The following is a description of a gene set: studied in species Homo sapiens Human Gene Set: GOCC_CULLIN_RING_UBIQUITIN_LIGASE_COMPLEX Any ubiquitin ligase complex in which the catalytic core consists of a member of the cullin family and a RING domain protein; the core is associated with one or more additional proteins that confer substrate specificity., and this is the list of marker genes: KLHDC10, DCAF7, FBXO17, CUL9, KLHL5, LRRC75A, SPOPL, FBXL16, FBXL6, ZSWIM5, DTL, FBXL13, FBXL3, KLHL12, CUL1, PRAMEF14, PRAMEF8, KCTD10, PRAMEF1, CRBN, KLHL18, FBXL21P, ANAPC15, FBXO31 (NCBI Gene Id 84204), DCAF11, BTRC, DMAC2, ANAPC7, KBTBD2, KLHL4, DDB2, CCNF, PRAMEF13, ARMC5, KLHL29, ARIH2, LZTR1, KLHL15, KLHL7, FBXO46, CCIN, KLHL40, FBXL7, DCAF1, FBXO44, SOCS2, PRAMEF11, PRAMEF10, CUL2, FBXO48, FZR1, KLHDC1, KLHL42, DCAF12L1, CUL7, FBH1, DDB1, CUL4A, FBXO9, ANAPC16, RNF7, ANAPC1, KLHL41, ANKRD9 (NCBI Gene Id 122416), PRAMEF6, KLHL24, SPOP, FBXO15, CDC16, DCAF13, FBXO39, SPSB1, PRAMEF15, KLHL28, FBXL15, KLHL25 (kelch like family member 25, NCBI Gene Id 64410), CKS2, KLHL13, DCAF4, FBXO42, TMEM183BP, WDTC1, ANAPC13, PRAMEF4, KCTD2, GLMN, FBXL14, KLHL6, USP47, UBE2C, PRAMEF12, KLHL11, PRAMEF27, PRAMEF26, PDCD6, WDR77, DCAF10, TNFAIP1, FBXW7 (NCBI Gene Id 55294), IVNS1ABP, FEM1C, CUL3, KLHL1, DCAF8L2, SKP1, BUB1B, KLHL3, KLHL35, ZSWIM8, PRAMEF20, APPBP2, KCTD13, CACYBP, CUL4B, KLHL38, ZER1, FEM1B, FBXW4, PRKN, FBXO4, KLHL23 (kelch like family member 23), FBXO7 (F-box protein 7), FBXO2, FBXW5, ARIH1, PRAMEF19, ZYG11B, CAND1, TRIM21, ELOC, KEAP1, ASB11, DCAF6, FBXO38, FBXO3, ANAPC2, KLHL2, PRAMEF7, FBXO6, KLHL30, COMMD1, CDC27, PRAMEF18, KBTBD8, ZSWIM4, PRAMEF17, ANAPC11, CDKN1B, DCAF17, SPSB3, ANAPC4, FBXO25, KBTBD12, FBXL17, TRPC4AP, ZSWIM6, DCAF12L2, DCAF8, DCAF16, KLHL10, SKP2, PEF1, DCAF15 (DDB1 and CUL4 associated factor 15), ENC1, KCTD5, PRAMEF2, RBX1, FBXO45, KLHDC2, FBXO24, ASB4, ERCC8, IPP, FEM1A (fem-1 homolog A), DCAF12, FBXW8, KLHDC3, SPSB4, PRAMEF25, ANAPC10, UBE2S, PRAME, FBXL19, FBXO27, DCAF5, KBTBD7, CDC26, DDA1, KLHL21, DEPDC5, KLHL20, ASB9, CDC20, SPSB2, ELOB, COP1, PRAMEF5, FBXW11, CDC20B, FBXL2, TMEM183A (NCBI Gene Id 92703), KLHL17, NCCRP1, KLHL9 (NCBI Gene Id 55958), ANAPC5, DAW1, SOCS7, AMBRA1, DCAF8L1 (NCBI Gene Id 139425), DCAF4L1, MAD2L2, DET1, CUL5, PRAMEF9, ZYG11A, PRAMEF22, GAN, FBXL4, FBXL5, KBTBD3, FBXL20, CKS1B, KLHL8, CDC23, KCTD17, DCAF4L2, PRAMEF33, AMN1, FBXO32, PCMTD1, KLHL22, KBTBD6